The following is a description of a gene set: species: Homo sapiens Human Gene Set: CUI_DEVELOPING_HEART_VALVAR_ENDOTHELIAL_CELL from publication Cui Y, Zheng Y, Liu X, Yan L, Fan X, Yong J, Hu Y, Dong J, Li Q, Wu X, Gao S, Li J, Wen L, Qiao J, Tang F (PMID 30759401), and this is the list of marker genes: SORD, HSPB8, PMP22, HS3ST1, STC1, ARID5A, NTRK2, TGFB3, PLA2G2A, ITPRIP, TUBB2A, CYSTM1, MT2A, RCAN1, GJA1, PKHD1L1, TMBIM1, CCL20, BEX1, NEAT1, TSPAN8, STARD7, AQP1 (NCBI Gene Id 358), EDIL3, CXCL2, NR4A2, C1QTNF1, NDP, MTMR11 (NCBI Gene Id 10903), ANK2, CD55, OLFML2A, PDLIM3, C7, HBEGF, DKK2, CEMIP2, HLA-B, F5, CLDN11, CXCL1, PLIN2, S100A10, SERPINF1, DUSP2, CRIP1, GABARAPL1, CDKN1A, CEBPD, CTSK, HSPA7, CTSL, ANGPTL2, NFATC1, CCL4, CD9, CRYAB, TNFAIP6, IGFBP5, NR4A3, PLCD1, NAMPT, MMP19, SLN, NFIL3, ANO1, NR4A1, CD44, BIK, OPTN, DKK3, DUSP5, CXCL8, MCL1, PDGFRA, ITGB4, SELL, PDLIM1, NET1 (neuroepithelial cell transforming 1), IGFL2, TIPARP, LDLR, AKR1B1, PENK, PLLP, CLIC2, SOD2, MAFF, PI16, ENDOD1, SERPINB1, ACSL1, CA5B, GADD45A, PLPP5, SIK1, RGS5 (NCBI Gene Id 8490), HLA-H, GATA4, THBD, PRNP, PNP, CYP1B1, ATF3, TAC1, CHMP1B (charged multivesicular body protein 1B), TUFT1, KLF9, S100B, EVL, S100A6, FEZ1, HAND2, RHOU, TPBG, GLT8D2, RGS4, GEM, HAPLN1, IFI27, S100A4, HEY2, SPOCK3, SOCS3, CD200, WNT4, PLAT, AOPEP, ASPN, PTHLH, ADAMTS1, PTGS2, FOSL2, TFPI2, ACKR3, CCDC3, APOLD1, IER5, VCAN